The following is a description of a gene set: Genes changed in Rat1a cells (fibroblasts) by overexpression of HMGA1 isoform b off a plasmid vector. from publication Hillion J, Dhara S, Sumter TF, Mukherjee M, Di Cello F, Belton A, Turkson J, Jaganathan S, Cheng L, Ye Z, Jove R, Aplan P, Lin YW, Wertzler K, Reeves R, Elbahlouh O, Kowalski J, Bhattacharya R, Resar LM (PMID 19074878) studied in species Rattus norvegicus Human Gene Set: HILLION_HMGA1B_TARGETS Although HMGA1 (high-mobility group A1; formerly HMG-I/Y) is an oncogene that is widely overexpressed in aggressive cancers, the molecular mechanisms underlying transformation by HMGA1 are only beginning to emerge. HMGA1 encodes the HMGA1a and HMGA1b protein isoforms, which function in regulating gene expression. To determine how HMGA1 leads to neoplastic transformation, we looked for genes regulated by HMGA1 using gene expression profile analysis. Here, we show that the STAT3 gene, which encodes the signaling molecule signal transducer and activator of transcription 3 (STAT3), is a critical downstream target of HMGA1a. STAT3 mRNA and protein are up-regulated in fibroblasts overexpressing HMGA1a and activated STAT3 recapitulates the transforming activity of HMGA1a in fibroblasts. HMGA1a also binds directly to a conserved region of the STAT3 promoter in vivo in human leukemia cells by chromatin immunoprecipitation and activates transcription of the STAT3 promoter in transfection experiments. To determine if this pathway contributes to HMGA1-mediated transformation, we investigated STAT3 expression in our HMGA1a transgenic mice, all of which developed aggressive lymphoid malignancy. STAT3 expression was increased in the leukemia cells from our transgenics but not in control cells. Blocking STAT3 function induced apoptosis in the transgenic leukemia cells but not in controls. In primary human leukemia samples, there was a positive correlation between HMGA1a and STAT3 mRNA. Moreover, blocking STAT3 function in human leukemia or lymphoma cells led to decreased cellular motility and foci formation. Our results show that the HMGA1a-STAT3 axis is a potential Achilles heel that could be exploited therapeutically in hematopoietic and other malignancies overexpressing HMGA1a., and this is the list of marker genes: ACHE, MYCN, PTMA, LIMK1 (NCBI Gene Id 3984), GPC1, TAC1, SOD1, CSF2, TNFRSF1A, MAK, CYP3A5, SLC6A11, CRIP2, RPL10, COX4I1, HSP90AB1, PDGFA, SLC25A5, RPS3A, ACADL, GFRA2, PCOLCE, RPL21, COX7A2 (cytochrome c oxidase subunit 7A2), ANXA5, GRM5, CD5, ID3, GPX4, NGF, CD80, UNC5A, CXCL10, ID2, ATP5MC1, PNLIPRP2, TK1, CD3G, CLU, PSMB4, RPL19, COX5A, MIF, CD44, SDC3, ATP5PD, DCC, NME1, GMFB, PNOC, COX5B, GABRR1, PLAUR, UNC5B, CCND3, RPL13, ID1, HRK, PCNA, ERBB2, AK3, ARF5, CTSV, NOS3, RPS12, EPHA3, HRAS, ACADVL, ATP5F1B, FGFR4, PSMB6, MGST1 (NCBI Gene Id 4257), STAT3, ANXA1, ALDH3A2, ATP5PB, ARF6, PSMA1, VCP, PSMA6, EPHA7, RPS11, CXCL2, AKR1A1